The following is a description of a gene set: Human Gene Set: HP_YELLOW_BROWN_DISCOLORATION_OF_THE_TEETH studied in species Homo sapiens Yellow-brown discoloration of the teeth, and this is the list of marker genes: SLC13A5, MMP20, KRT14, KLK4, SLC24A4, FAM20A, ITGB6, CNNM4, DLX3, SATB1, ENAM, ROGDI, RELT, DSPP, HMBS